The following is a description of a gene set: studied in species Homo sapiens An abnormality of the hindbrain, also known as the rhombencephalon. Human Gene Set: HP_ABNORMAL_HINDBRAIN_MORPHOLOGY Abnormal hindbrain morphology, and this is the list of marker genes: ALDH18A1, KNL1, GON7, GRIA2, DYNC2H1, ACBD6, PPP2R2B, USP8, DYNC2I2, STT3B, NGLY1, GPKOW, WAC, AP4B1, NPHP3, SNAPC4, KIF5A, SDHA, NKX6-2, CHP1, SUFU, B9D1, POLA1, USH1C, TBCE, CCDC32, NAA60, EXOSC5, PIGT, MBD5, CEP120, GPSM2, IFRD1, CEP41 (NCBI Gene Id 95681), MRM2, NDE1, TRPC3, INPP5E, DHX37, BCL11A, RBM10, MME, AFG3L2, SAMD9L, GRIN1, ATG7, ATN1, IFT172, RBBP8, CPLANE1, VARS1, GOT2, AHDC1, TERT, TRMT1, PCGF2, RNF216, CDC45, PIGS, WNT1, POLR3A, SDHD, SNX14, LMNB1, SLC9A1, ZNF423, NEK1, HK1, ATR, PGAP2, TMEM231, ZMIZ1, MAPKAPK5, MED23, PORCN, CLIP2, GLS, MFSD8, FGFR1, WASHC5, SNUPN, KCNJ10, AP4S1, CHD7, TRAPPC9, KARS1, ARG1, CLXN, TREX1, YRDC (yrdC N6-threonylcarbamoyltransferase domain containing), PI4KA, DNAJC30, GPX4, VPS41, TMEM237, ATP6AP2, ATXN1 (ataxin 1), WDR26, BMP4, TMEM94, DNMT3A, MVK, NRAS, CLCN3, MFSD2A, RBM8A, NFKB2, AHCY (adenosylhomocysteinase), VRK1, PEX6, CARS1, TWIST1, H3-3A, MAN2C1, PI4K2A, ZSWIM6, CLN3 (NCBI Gene Id 1201), CNTNAP2, TAPT1, LAMA1, ARSI, NARS2, STAT3, STXBP1, RTTN, POLG2, CTCF, ARNT2, PDGFB, DNM1L, INTS11 (integrator complex subunit 11), ROBO3, LARGE1, POLR3B, APTX, GRN, SCO2, COG5, MGME1, FA2H, OXR1, PDE6D, TRIP13, PIGK, DYNC2I1, SPATA7 (NCBI Gene Id 55812), VLDLR, SKI, GDF6, ZNF592, PIK3R5, FKBP6, ATAD3A, MICU1, SLC20A2, TBC1D24, CRB1, CC2D2A, NADK2, DNAJC5, KATNIP, CERS1, CASK, PRDM13, ANO10, TTPA, SOX11 (NCBI Gene Id 6664), MED12, TECPR2, TUBB4B, CMPK2, PCYT1A, AGTPBP1, AP4E1, SMARCC2, SUOX, WDR45, COL18A1 (collagen type XVIII alpha 1 chain), SLC35B2, RAB3GAP1, GAD1, UBE3C, NAXE, TAOK1, SLC31A1, TNPO2, USF3 (NCBI Gene Id 205717), ATP6V1E1, TRMT10A, C19orf12, SIL1, DNAJC3, MICOS13, HEXB, NDUFA6, MED27, AHI1, PRKCG, PLD3, ATXN3, RPS6KA3, TPP1, DNMT1, SLC30A7 (solute carrier family 30 member 7), RPE65, DYNC1H1, ADGRG1, NIPBL, ATXN10, RNF13, ALX4, ARID2, B9D2, RNASEH2A, EZH2, PLK4, CDC42, OCLN, ELOVL4, OSGEP, SACS, CEP85L, AP4M1, TFAP2A, ROGDI, FANCL, TERC, OFD1, CCND1, EVC, CTBP1, ZFYVE26, DHCR7, CTSF, CNTNAP1, NDUFA8, CPT2, UBE2A, VANGL1, SEC23B, ZBTB11, B4GALT1, EXOSC9, ERCC5, CHD8, LRRC32, NFASC, SLC39A8 (solute carrier family 39 member 8), MARS2, C2CD3, BCORL1, GMPPB, DKK1, NUP88, TSEN34, LIPT1, CDH23, KDM6A, MGAT2, PCLO, MUSK, COG1, SMC1A, TBL1XR1, MAPK8IP3 (mitogen-activated protein kinase 8 interacting protein 3), NDUFS4, PRNP, PLA2G6, EEF2, GFM2, TGFBR1, YIF1B, TGFBR2, RNU4ATAC, HNRNPR, PAX2, MYO7A, RFX7, MBTPS2, SLC25A19, UBA5, NDUFA1, COQ9, USH1G, COL4A1, CIZ1, ERCC1, MINPP1, PEX10, CSF1R, COG8, DHFR, MYOD1, BCAS3, NMNAT1 (NCBI Gene Id 64802), XRCC1, SMG9, ARL13B, LYRM7, COG6, ATPAF2, TONSL, SCN1A, RXYLT1, TMEM270, VPS35L, CLN5, JAM2, RAD21, SMC3, SLC1A3, SPTBN2, PRRX1, SLC25A1, KPNA3, GLI3, KCTD7, VPS13B (NCBI Gene Id 54990), DISP1, SDHC, POLR1C, IGF2 (insulin like growth factor 2), FOSL2, CNP, LETM1, FANCB, RAPSN, POMGNT2, EXOSC2, DKC1, TOP3A, FAT2, SUMF1, TMEM240, ATP1A3, PTEN, FUS, TARS1, WDR37, RPL10, LIG3, NOVA2, CLCN7 (NCBI Gene Id 7814), GTF2H5, SIGMAR1, CRX (NCBI Gene Id 1406), SPART, NOP10, NALCN, DMXL2, KIF14, CHD6, KCNH5, BAZ1B (NCBI Gene Id 9031), CCDC47, TOR1A, SOX4, KIAA0753, FUZ, APC2, ARF1, ASXL1, RARS2, TOGARAM1, NUBPL, HESX1, AARS1, B4GALNT1, GDAP2, KIDINS220, NDUFS1, LAMB1, STAT2, SPG11, EXOC7, PHGDH, PLCH1, ALG9, EBF3, CAMSAP1, FCSK, STX1A, FARS2, MAST1, MPL, AIMP2, ZIC2, FGF12, PRUNE1, PIGQ, SLC52A3, ACO2, TRIM8, THG1L (tRNA-histidine guanylyltransferase 1 like), MEF2C, EIF4H, DHX30, TSEN2, FAT4, FTL, MKS1, SLC32A1, ADGRV1, PPP2R1A, DDX3X, B4GAT1, TOPORS, PACS1, MYH3, ATP6V1B2, TMX2, NOTCH3, STT3A, MCOLN1, TUBB3, BICD2, MYMX, FBXL4, NF2, POLG, CLPB, THOC2, NEUROD2, CKAP2L, TAF1, BCAP31, CEP55, SMARCA2, TMTC3, DHX9, TEFM, USP45, MDH2, DPH1, TXNDC15, PIBF1, CUX2, PLP1, TAF4, MAF, ZPR1, MT-CYB (NCBI Gene Id 4519), SC5D, NCAPG2, CACNA1A, POR, DPM2, DENND5A, KLLN, TTBK2, INTS8, HNRNPH1, TSEN54, COA7, CDON, ATP13A2, DPAGT1, FKTN, ESPN (espin), TUBB2B, CAMLG, SMARCD1, PRKDC, PARN, IBA57, ASPM, NSUN6, CCDC88C, SLC35A2, COG7, GRID2, DEGS1, NUP133, STIL, BUB3, PRRT2, KAT5 (lysine acetyltransferase 5), TK2 (thymidine kinase 2), ERCC3, PPP1CB (protein phosphatase 1 catalytic subunit beta), TAF6, SON (NCBI Gene Id 84155), NCF1, TUBA1A, BTD, SLC19A1, TBCD, IFT74, NSRP1, RECQL4, FLVCR2 (NCBI Gene Id 55640), SPRED1, PCNA, TRAPPC11 (trafficking protein particle complex subunit 11), CARS2, DPYSL5, USP9X, TBCK, MAGEL2, DOCK7, TRPM3, GFAP, PHEX, KATNB1, TGM6, FXN, HMGA2, SYT2, PDYN, ERF, CDKN1C, AFF3, WDR35, UFC1, PMPCA, KIF1A, SCN1B, GNAQ, DCC, TBC1D20, ALG6, ABHD12, TMEM67, DOK7, MYORG, FANCI, NAGA, LMX1B, PPP1R15B, ATCAY, POU4F1, MAN1B1, CWC27, CWF19L1, PCDH15, TRAPPC12, ERCC8, ATP6V0A2, MAP3K7, CRPPA, FDXR, LIMK1, POLR1A, KRAS, STUB1, ATP5F1A, EXOSC3, SF3B2, LHX4, SETX, CBY1, COQ5, HLA-DQB1, FBN1 (fibrillin 1), SDHB, PTCH1, ARHGEF2, SNF8, ATP2B3, MYMK (myomaker, myoblast fusion factor), MAB21L1, VHL, SOX2, TINF2, CHD4, KIAA0586 (NCBI Gene Id 9786), POMT2, GLI2, TGIF1, OPA3, MYO5A, PDHA1, WDR81, RNF170, PPP1R21, SMO, ZFHX3, RDH12, VPS50, ERCC6, FOXF1, STAG1, USP18, BCS1L, VPS4A, ACTL6B, TRRAP, PIGU, CYB5A, RHOBTB2, PIGP, TBL2, IMPDH1, RFC1, COL3A1, BRD4, RAB34, PEX2, RBL2 (NCBI Gene Id 5934), FTH1, PNKP, POU1F1, RAD51, OTUD5, KCNMA1, ATXN8OS (ATXN8 opposite strand lncRNA), EXOSC1, GEMIN4, VPS51, CCDC88A, ATP1A2, SMARCA4, YME1L1, ABCB7, SIK1, SIK3 (NCBI Gene Id 80236), MACF1, OPHN1 (oligophrenin 1), RRM2B, COG3, FGFR2, FRMD4A, GBA2, PIGN, ATP5MK, LEMD3, SLC25A22, GRM1, SCYL1, NSD1, CYP7B1, PDGFRB, SYT14, PPIL1, ERMARD, PGAP1, TBP, GRM7, NSD2, TXN2, CYFIP2, EXOC2, MID1, SCN8A, RNF113A, PMPCB, CDKL5, FGF14, KMT2D, HEPACAM, MTHFR, SH2B1, BCOR, ODC1, RNU4-2, NDUFA13, GTF2IRD1, ALG1, CDC42BPB, COX20, SPTAN1, NPTX1, GRIA3, TOE1, SHQ1, SQSTM1, PTF1A, TP53RK, ALG3, L2HGDH, WWOX, NELFA, CRAT, HMBS, RTEL1, CAPN1, FOXC1, CUL4B (NCBI Gene Id 8450), KANSL1, KIF21A, GTF2E2, COASY, ZIC3, ADSL, DLL1, OPA1, RFWD3, PLAAT3, RAC1, ATP6V0A1, TRAPPC6B, TMEM218, ITPR1, SLC44A1, FAR1, DPH2, CAMTA1, KY, HNRNPH2, TKFC, BAP1, KCNC1, KIF7, RNASEH1, ACD (NCBI Gene Id 82538), EBP, SRD5A3, SRPX2, LRPPRC, BUB1B, GJB6, PTRH2, TUBB4A, TRAPPC4, MRE11, PDHX, KIF1C, CTNNA2, WLS, NFIX, MPLKIP, EOMES, FLI1, DLG4, LYST, DCLRE1B, ARX, SCN2A, PPP1R12A, UCHL1, CILK1, ABCD1, LAMA2, MECR, VAC14, FIG4, TUBB2A, CIT (citron rho-interacting serine/threonine kinase), VPS53, WDR73, TSEN15, CTSK, IRF2BPL, CENPE, SOD1, TCTN1, SEPSECS (NCBI Gene Id 51091), FKRP, MAG, EN1, ERCC2, PNPLA6, ADPRS, AMPD2, TULP1, VPS37D, LONP1, GAS1, ERLIN1, SPG7, PROKR2, AARS2, ENSG00000288330, CENPF, RELN, RAP1B, MLXIPL, BLTP1 (bridge-like lipid transfer protein family member 1), HERC1, TMEM216, GJB1, GTPBP2, PIGA, PITRM1, ALG12 (ALG12 alpha-1,6-mannosyltransferase), STAG2, COQ4, DAG1, AIPL1, FOXRED1, PLAA, IFT80, MRPS34, SLC25A24, CRIPTO (cripto, EGF-CFC family member), EMC1, MAP2K2, ATP8A2, SMARCE1, TRAF7, RAB3GAP2, EVC2, CREBBP, PACS2, IDH1, B3GALNT2, CLTC, LAGE3, KCNA1 (potassium voltage-gated channel subfamily A member 1), PDCD6IP, DPM1, PIGG, SOX3 (SRY-box transcription factor 3), RPGRIP1, SCAF4, CCDC22, DOCK6 (dedicator of cytokinesis 6), BEAN1, INTS1, IFIH1, TTC19, IQCB1, CEP164, ESCO2, ARMC9 (NCBI Gene Id 80210), EPG5, FMR1, PROP1, PPFIBP1, NDUFA9, HES7, WHRN, KMT2C, SERAC1, GUCY2D, SETD2, METTL27, BUB1, LCA5, DHDDS, ATP9A, AKT1, TSPOAP1 (NCBI Gene Id 9256), ELOVL5, DPH5, EPRS1, CACNA1G, PIK3CA, GPC4, NOTCH2, ARID1A, BRAT1, SEMA3E, FTO, PEX16, GNS, POMK, TCTN2, PMM2, SMPD4, JAM3, MORC2, NODAL, PLG, SASS6, IL11RA, DCHS1, ATXN7, TDP1, TBC1D23, CEP57, FGF8, SETBP1, UFM1, RERE, SEMA6B (semaphorin 6B), FGFR3, FLNA, TBC1D2B, CPSF3, COQ8A, RUBCN, GTF2IRD2, GPHN, RD3, ATP5F1D, BRF1, ARL3, TWNK, MTHFS, KDM1A, FAM149B1, SNORD118, DARS2, ATXN2, KCNQ1OT1, ZEB2, NOTCH2NLC, GTF2I, CDK5, TCTN3, RORA, SPG21, SLC25A46, DAB1, CAMK2B, NDUFAF4 (NCBI Gene Id 29078), CDC40, SYNE1, HSD17B4, GPC3, RNU12, NONO, CSPP1, DACT1 (NCBI Gene Id 51339), KCND3, GRIK2, ARCN1, ALDH5A1 (NCBI Gene Id 7915), NUP37, SLC25A4, CLN8, SALL1, AP1S2, GALC, HYLS1, NOP56, RFC2, PIEZO2, ASNS, NPHP1, OTX2, HDAC8, TMEM138, KCNJ13, CIB2, L1CAM, GJB2, SMPD1, ZIC1, SLC33A1, SH3TC2, EP300 (E1A binding protein p300), ATG5, QARS1, NUP214, IFT140, TMEM107 (transmembrane protein 107), CEP290, RRAS2, ROBO1, DPF2, HDAC6, CEP104, GNAO1, ALS2, XRCC4, ATP6V1A, PTH1R, WDR4, EXOSC8, CYP27A1, CP, GJA1, MAN2B1, WARS2, LRAT, HDAC4, MT-ATP8, TMCO1, SMARCB1, RAB18, PSAT1, ARID1B, SLC9A6, DEPDC5, KCNQ1, TUBGCP6, MDH1, SIX3, ASXL3, LNPK, SCARB2 (NCBI Gene Id 950), SLC39A14, CYB5R3, PDHB, ABAT, NDP, COX4I1, GAN, EHMT1, HHAT, UFSP2, POMGNT1 (NCBI Gene Id 55624), PEX11B, REPS1, USH2A, MED11, SHH, NFIA, SLC18A3, HRAS, MSTO1, COQ2, HTT, AP3B2, POMT1, MTM1, HYCC1, KCNC3, ZNHIT3, BUD23 (NCBI Gene Id 84118), TUBB, PAFAH1B1, CACNA2D2, ACY1, MFF, SLC13A3, IER3IP1, VWA3B, VANGL2, PDZD7, RPGRIP1L, PRDX3, CTSD, CAPRIN1, RAB11B, TUBGCP4, POGZ, CPLX1, VPS13D, VPS11, MT-ATP6, SLC5A6, SPTLC1, GEMIN5, POLR3K, ATP5F1E, EIF4A2, PNPT1, ELN, CHMP1A, FRRS1L, ZNF335, GPAA1, UBTF, FOXH1, LHX3, ZNF292, BICRA, SRPK3, DOHH, VARS2